The following is a description of a gene set: Mouse Gene Set: GOMF_ODORANT_BINDING species: Mus musculus Binding to an odorant, any substance capable of stimulating the sense of smell., and this is the list of marker genes: Or5w20, Or5p59, Vmn1r7, Or5h26, Vmn1r197, Or9k2, Or5w22, Or9i16, Vmn1r185, Or9e1, Or8g37, Vmn1r6, Vmn1r24, Or14c40, Or8g28, Or5w12, Or5b3, Or5ac19, Or14p1, Or5m9b, Or14a257, Or8b8, Or8g55, Or8g4, Gm15433, Or8c9, Or12d13, Vmn1r193, Vmn1r201, Or8g34, Or5af2, Or8b35, Or8b46, Mup7, Vmn1r22, Vmn1r212, Or5an1c, Or9r3 (olfactory receptor family 9 subfamily R member 3), Or8b12, Or5ar1, Vmn1r195, Or5w8, Vmn1r74, Or8c15, Or9r7, Or10aa3, Or12d15, Or12d2, Or5w10, Vmn1r35, Gm14744, Or12j3, Or5p62 (olfactory receptor family 5 subfamily P member 62), Or5d36, Or8g33, Or9s15, Or5e1, Or13g1 (NCBI Gene Id 258196), Or8c13, Or8g52, Obp1a, Or12j2, Or13a24, Or5j3, Vmn1r229, Or10j7, Or5b104, Or5p56, Or5p52 (olfactory receptor family 5 subfamily P member 52), Or5b121, Or5b119, Vmn1r188, Or5p76, Or8g54 (NCBI Gene Id 258823), Obp2b, Mup2, Vmn1r75, Or12d16-ps1 (olfactory receptor family 12 subfamily D member 16, pseudogene 1), Or13l2, Or10v9, Or5p53, 5430402E10Rik (RIKEN cDNA 5430402E10 gene), Or8g26, Or10k2, Or5w16, Or5af1, Vmn1r206, Or5m3, Or9i1b, Or8d1, Or5an6, Vmn1r73, Or14j3, Or5ak20 (NCBI Gene Id 258166), Mup13, Or5ak25, Or5m5, Or5ac25, Or5t17, Vmn1r234, Or6k2, Or9m2, Or5b97, Or14a259, Mup21, Vmn1r78, Or14c39, Lcn3, Or5an1, Or4e2, Lcn4, Or5ac22, Vmn1r226, Or10b1, Or9g4, Or11q2, Or8c18, Or13a17, Or8g20, Mup22, Vmn1r83, Or5w1b, Or9g8, Or5d37, Or8h9, Or5b98, Or14c41, Vmn1r33 (NCBI Gene Id 171187), Vmn1r202, Or5c1, Vmn1r214, Or8h10, Or5l14, Or5k15 (NCBI Gene Id 258999), Or8h6, Or8b12b, Or5d43, Or5b118, Vmn1r19, Or5ak22 (NCBI Gene Id 258865), Or5p6, Or9i1 (NCBI Gene Id 258793), Or14a256, Or5b99, Or5b106, Or5i1, Or5t7, Or5k8, Or9g3, Or5ac17, Or13a27, Or5b95 (olfactory receptor family 5 subfamily B member 95), Or13a21, Or13a28, Vmn1r210, Or5p54, Or5as1, Vmn1r32, Lcn11, Or5b122, Or5be3, Vmn1r213, Or8h7, Or10q1, Or8b9, Or6k4, Or5b107, Vmn1r196, Or6k14, Or14c45, Or5p55, Vmn1r36, Vmn1r23, Or5d46, Or8b38, Or5d16, Or5ac21, Gm7609 (NCBI Gene Id 665378), Mup18, Or8c20, Or5d40, Or13a19, Or6k6, Or14j2, Or11l3, Or5g23, Vmn1r208, Or5m8, Or5p78, Or8b36, Or6b2b, Or8d1b, Or5p61, Or5p4, Or5k16, Or9s14, Or14a258, Or5w11, Or5m9, Or5k3, Vmn1r233, Or8g32, Or5aq6 (olfactory receptor family 5 subfamily AQ member 6), Or8g18, Vmn1r219 (NCBI Gene Id 171272), Or12d12, Or10p22, Or5w14, Vmn1r80, Or5bb12, Or8b55, Or10v5, Or9i2, Or5g29 (olfactory receptor family 5 subfamily G member 29), Vmn1r235, Or9q2 (olfactory receptor family 9 subfamily Q member 2), Or13a20, Or5an1b, Obp1b, Or5ap2, Vmn1r37, Or8g23, Vmn1r82, Or5d18, Or10p21, Or5p63, Vmn1r198, Or13a1, Or8b48, Or5bw2, Or5m3b, Or10q12 (olfactory receptor family 10 subfamily Q member 12), Or5p51, Mup14, Or8c16, Vmn1r76, Or5b105, Or9s18, Or5w13, Vmn1r215, Or5t9, Gm7582, Or5ak23, Or8b57, Or8g2b, Vmn1r191, Or8c11, Mup11, Or2j6, Gm5938, Or5p69, Vmn1r18, Vmn1r66, Or5p50, Or5t15, Or8c8, Or5p70 (olfactory receptor family 5 subfamily P member 70), Or5k14, Or5p80, Or8b52, Or5d39, Or5w17, Or9g19, Or2c1, Or8b51, Or5b94, Or8c17 (olfactory receptor family 8 subfamily C member 17), Or8d6, Vmn1r236, Or5p67, Or8b49, Gucy2d, Mup4, Vmn1r192, Or5p81, Or8b54, Vmn1r70, Or12j4, Or8b56, Vmn1r200, Mup8, Or14j6, Or5m13, Or5b113, Or8b50, Or12d17, Or5w15, Or5j1, Or8g17, Or8b37, Mup1, Or9g4b, Vmn1r231, Or5b109, Or8g35, Or5p5, Or14c46, Or6b6, Vmn1r26, Or14j10, Or5m13b, Or5d41, Or9s13, Or5b24, Or5p72, Or9s27, Or8c10, Or5h19, Or8g51, Or5w19, Vmn1r199, Or5p66, Or5p60, Or5g25, Or5b12b, Or5an11, Or5p58, Or8g36, Mup6, Or5b117, Or8b3b, Or5m10, Or8b39, Mup10, Vmn1r232, Vmn1r89, Vmn1r87, Vmn1r9, Or5ac23, Vmn1r220, Or5d20-ps1 (olfactory receptor family 5 subfamily D member 20, pseudogene 1), Or8g21, Or8g24, Vmn1r203, Or5ae1, Or5ac20, Or8g30, Or5g9, Or5a3, Or14j4, Or5d35, Vmn1r8, Or8b101, Vmn1r211 (vomeronasal 1 receptor 211), Or9m1, Or8s5, Or5d47, Or8g50, Or6b2, Or12d14-ps1, Vmn1r190-ps, Or5d38, Vmn1r21, Vmn1r225, Or5g27, Vmn1r81, Or5b96, Or5b102, Vmn1r4, Vmn1r38, Or8b3, Or8g2, Or9i14, Or9q1, Or8g53, Or10q3, Vmn1r205, Vmn1r16, Or5p79, Or14j8, Or5b12, Or8b12c, Vmn1r217, Or5aq7, Pbsn, Or8a1b, Or5h17, Or5m12, Or5p68, Vmn1r227, Or10w3 (NCBI Gene Id 258735), Or8g19, Or5p1, Vmn1r28, Mup17, Or8g27, Or8b42, Or5ak24, Vmn1r237, Or8h8, Or9k2b, Gm14743, Or5an10, Or10q1b, Or6n2, Or5aq1, Or5t5, Or5au1, Or10j27, V1rg10, Or8b1, Or8d2, Or5ac15, Or5h25, Or5d14, Or5t16 (NCBI Gene Id 258584), Or5b112, Or5d45, Or9m1b, Or14c43, Or8a1, Or8b44, Or8d23, Or1r1, Or5t18, Or8b40, Or8b1b, Or10j3, Or5b123, Or5b124, Or5a21, Or9k7, Or8b4, Or6b3, Or8b53, Or13a25, Or5an9, Or5ak4 (NCBI Gene Id 257951), Or13a26, Mup20, Or10v1, Or5k17, Or14j9, Or5aq1b, Or5ac24, Vmn1r222, Or8b47, Or5p73, Or14j1, Or14j5, Or5h18, Vmn1r67, Or5bh3, Or5w18, Or5b108, Or5b21, Vmn1r30, Vmn1r5, Or5w1, Or10j3b, Or5l13, Or8b1c, Or5a1, Or5d44, Vmn1r17, Or5ae2, Or5p64, Or5bb10, Or5p57, Or5h22 (olfactory receptor family 5 subfamily H member 22), Vmn1r216, Or5ac16, Mup15, Vmn1r27, Or8w1, Or13a18, Or5b101, Or5k1b, Or10aa1, Mup3, Vmn1r228, Or5g26, Or5d3, Vmn1r189, Or8b43, Or5k1, Vmn1r230, Mup5, Or14c44, Or9s23, Or12j5, Or5b116, Vmn1r218, Or14a260, Or5m10b, Or5h23, Or13a22, Or4e1, Or5b111, Vmn1r84, Or8i2, Or8b41, Or14j7, Or4e5, Or11n2, Or5b120, Or8d4, Or8d2b